Given this list of marker genes ANO9, ANO6, ANO7, PLSCR4, ANO4, ANO3, here is a description of the gene set: Human Gene Set: GOBP_CALCIUM_ACTIVATED_PHOSPHOLIPID_SCRAMBLING species: Homo sapiens The movement of a population of phospholipid molecules from one leaflet of the plasma membrane bilayer to the opposite leaflet as a result of a calcium stimulus.